Given this list of marker genes FXYD2, OTOP3, RASAL1, NOS2, NRXN2, SLC6A3, CGREF1, SCRT2, TBX3, DRC12, SSH1, FAM169A, EFCC1, DLK1, FSIP2, JAKMIP1, BVES, BSN, GHSR, CDK20, NLRC3, CD274, TMEM182, PSMB8, CPXCR1, SLC25A33, CSMD1, MAPK8IP2, TAFA2, RNF186, HCRTR1, TIFAB, MYCL, GRID2IP, CTRC, PITPNM3, CAMKV, LHX3, ARL13A, TRPM2, GLIS1, ANKDD1A, GNB1L, HSDL1, C1QA, FGD2, STOX1, RIPK3, SSTR3, APOC1 (apolipoprotein C1), CD247, FEZF2, BTBD17, PRDM1, NFAM1, MGAM, RUNDC3A, A2M, FBXL16, H1-10, FOLR1, SERPINE2, ASPHD1, ARPP21, CORO1A, XCL1 (X-C motif chemokine ligand 1), SLC7A2 (NCBI Gene Id 6542), BCR, GPR139, GCKR, MIR296, STRC, MOBP, LRRC3B, DHX32, LY6G6F, CARD9, SPON1, TENT5D, KIRREL2, XDH, HR, SCARF1, SCUBE1, FETUB, BATF3, MAL, FCGR3A, SNHG11, CD3G, ADAMTS16, RUNX3, CD86, NFE2L3, DISP3, CCR8, IFITM1, CBLN4, PSMB9, THBS4, ISG15, ADAMTS15, PCP2, PSD, ZBTB42, SFTPA1, SLC66A2, LIN28A, TAS1R2, CD163L1, DUSP13B, TH, DRD4, UBE2QL1, FAM163B, PHEX, SELPLG, CLEC4D, CD276, THSD7B, TAFA3, FBXL22, ADGRD1, MRAP2, PTH1R (NCBI Gene Id 5745), AMIGO1, KRT13, SP9, SLC13A5, GPBAR1, IL27RA, F2, GDNF, VWA3A, PLA2G7 (phospholipase A2 group VII), BTBD6, GPRIN1, PLD2, SPACA4, PDZD4, MYO1F, EFNA3, SLAMF8, GAS2L2 (growth arrest specific 2 like 2), OPRD1, PIK3R5, here is a description of the gene set: from publication Hodges A, Sharrocks K, Edelmann M, Baban D, Moris A, Schwartz O, Drakesmith H, Davies K, Kessler B, McMichael A, Simmons A (PMID 17496896) Human Gene Set: GSE6090_UNSTIM_VS_DC_SIGN_STIM_DC_DN Genes down-regulated in dendritic cells: control versus stimulated with anti-CD209 antibody. studied in species Homo sapiens DC-SIGN is a C-type lectin expressed by dendritic cells (DCs) that binds HIV-1, sequestering it within multivesicular bodies to facilitate transmission to CD4+ T cells. Here we characterize the molecular basis of signalling through DC-SIGN by large-scale gene expression profiling and phosphoproteome analysis. Solitary DC-SIGN activation leads to a phenotypically disparate transcriptional program from Toll-like receptor (TLR) triggering with downregulation of MHC II, CD86, and interferon response genes and with induction of the TLR negative regulator ATF3. Phosphoproteome analysis reveals DC-SIGN signals through the leukemia-associated Rho guanine nucleotide exchange factor (LARG) to induce Rho activity. This LARG activation also occurs on DC HIV exposure and is required for effective HIV viral synapse formation. Taken together HIV mediated DC-SIGN signalling provides a mechanism by which HIV evades the immune response yet induces viral spread.